Given this list of marker genes H2-M3, Lingo1 (NCBI Gene Id 235402), Mtm1, Epha7, Stambp, Sfrp5, Them4, Sco1, Drd3, Nop53, Dag1, Smpd3, Sirt1, Nherf2, Lemd2, Btn2a2, Serpine2 (NCBI Gene Id 20720), Tsc2, Otud3, Ptprj, Cib1, Phlpp1, Ppp2ca, Rack1, Plk3, Sh2b3, Obscn, Ppp2r1a, Rapgef1, Mul1, Nlrc3, Mmp3, Cryba1, Gper1, Klf4, Inpp5k, Dab2ip, Nherf1, Cdkn2a, Flcn, Pik3cb, Mir423, Igf1r, Ddit3, Dlg1, Drd2, Bank1, Xdh, Plekha1, Ncor1, Mstn, Cntnap2, Trem2, Ppara, Pkhd1, Sirt7, Pik3ip1, Twist1, Phlda3, Magi2, Lox, Mir143, Pdcd6, Pten, Hyal2, Wdr91, Usp49, Inpp5e, Ptpn1, Rubcn, Cavin3, Aim2, here is a description of the gene set: Mouse Gene Set: GOBP_NEGATIVE_REGULATION_OF_PHOSPHATIDYLINOSITOL_3_KINASE_PROTEIN_KINASE_B_SIGNAL_TRANSDUCTION Any process that stops, prevents, or reduces the frequency, rate or extent of phosphatidylinositol 3-kinase/protein kinase B signal transduction. studied in species Mus musculus